Given this list of marker genes Abcb11, Xylb, Dpep2 (NCBI Gene Id 319446), Acad8, Adtrp, Ivd (NCBI Gene Id 98988), Ppard, Lpin1, Uroc1, Slc27a4, Naalad2, Ldhd, Arg1, Cryl1, Pck1, Aass, Nagk, Klf9, Acsl5, Abcd2, Acot8, Twist1, Acoxl, Acadm (acyl-Coenzyme A dehydrogenase, medium chain), Cyp4f18, Sord (NCBI Gene Id 228568), Ldhc, Acot7, Hao1, Pex7, Pck2, Nos2, Got2, Dlat, Cyp39a1, Kynu, Nudt8, Kmo, Cyp4f14, Abcd1, Cyp4f40, Eci2, Lipe, Acox1, Acat1, Mat1a, Gls2, Pipox, Bckdk (NCBI Gene Id 12041), Agxt, Ddah1, Bcat1, Ilvbl, Etfbkmt (electron transfer flavoprotein beta subunit lysine methyltransferase), Hal, Fabp1, Ppm1k, Lpin3, Acads, Mlycd, Tha1, Otc, Sardh, Nos1, Hoga1, Ido1, Hibadh, Aldh4a1, Dpep1, Mtor, Cyp4f15, Tat, Qdpr, Slc16a3, Kyat1, Irs2, Pex13, Cpt1b, Dbt, Kyat3, Asrgl1, Echs1, Abcd3, Acot4, Gpt2, Slc25a17, Scly, Cpt1a, Mtrr, Plin5, Nos3, Tdh, Mccc2, Bckdhb, Crat, Gcsh, Ces1f, Hibch, Cyp2w1, Oaz1, Ces1d, Slc25a44, Sesn2, Arg2, Gstz1, Decr2, Renbp, Ftcd, Acad12, Ddo, Dlst, Eci3, Akr1a1, Abat, Tdo2, Dld, Cyp26a1, Hadha, Adhfe1, Lep, Slc16a1 (NCBI Gene Id 99768), Sp1, Gad2, Fah, Acacb, Abhd3, Aldh1l1, Npl, Lonp2, Agxt2, Acad9, Acaa1b, Aldh5a1, Acsbg2, Mfsd2a, Abhd1, Cyp4f13, Blmh, Irs1, Aldh1l2, Glud1, Aldh6a1, Il4i1, Bckdha, Shmt1, Csad, Hdc, Eci1, Abcd4, Scp2, Atp2b4, Phyh, Akt2, Qprt, Amdhd1, Obp2a, Ehhadh, Bdh2, Pex5, Cyp26b1, Aadat, Ahcyl, Amt, Cyp26c1, Aig1, Echdc2, Pm20d2, Gcat, Acox2, Gnpda2, Acad11, Etfdh, Nudt7, Gnpda1, Acad10 (acyl-Coenzyme A dehydrogenase family, member 10), Ech1, Got1, Ido2, Hsd17b10, Pon3, Etfb, Tysnd1, Aldh8a1, Slc27a2, Mccc1, Gcdh, Hacl1, Mtln, Sult2a8, Acmsd, Hgd, Acadsb, Pex2, Ppat, Gad1, Adipoq, Auh, Ahcy, Sds, Cbs, Acadvl, Acsf3 (NCBI Gene Id 257633), Amdhd2, Hsd17b4, Akt1, Acadl, Prodh2, Cnr1, Cdo1, Crot, Dao, Haao, Afmid, Strap, Acaa2, Hadhb, Mthfsl, Lpin2, Decr1, Aasdhppt, Hpd, Dcxr, Oat, Gldc, Faah, Gls, Pah, Prodh, Bcat2, Akr1d1, Acaa1a, Echdc1, Abhd2, Sdsl, Dbi, Hmgcll1, Cpt2, Hadh, Nudt19, Thnsl2, Ldha, Gpt, Acox3, Hmgcl, Etfa, Pon1 (NCBI Gene Id 18979), here is a description of the gene set: Mouse Gene Set: GOBP_ORGANIC_ACID_CATABOLIC_PROCESS The chemical reactions and pathways resulting in the breakdown of organic acids, any acidic compound containing carbon in covalent linkage. studied in species Mus musculus